The following is a description of a gene set: species: Homo sapiens Human Gene Set: GOMF_STRUCTURAL_CONSTITUENT_OF_CYTOSKELETON The action of a molecule that contributes to the structural integrity of a cytoskeletal structure., and this is the list of marker genes: GFAP, MSN, TUBB8, KRT15, CD2AP, ACTL7B, DSP, PLS1, VIM, TUBB1, SPTAN1, ACTR3, KRT19, TUBA8, INA, ARPC4, KRT2, POTEE, TUBA3C, TUBA1C, PLEC, PPL, NEFM, BFSP1, ACTL8, SPTBN1, KRT31, KRT9, YEATS4, ACTN2, POTEKP, KRT84, SPTB, LMNB2, ADD2, SPTBN4, BFSP2, ACTR2, TUBA1B, TUBB8B, TLN2, TUBB3, POTEF, EPB41L3, ACTG1, MYL9, SPTBN2, CCDC6, SPTA1, SYNM, LMNB1, TUBB4B (NCBI Gene Id 10383), CYLC1, TUBA4A, PRPH, TUBAL3, KRT14, EPB41L4B, TLN1, ANK1, TUBB6, TUBD1, KRT6B, TPM1, KRT5, TUBA3D, DMD, ARPC5, POTEJ, ACTA1, TUBGCP3, SORBS3, ARPC1B (actin related protein 2/3 complex subunit 1B), POTEI, CROCC, KRT6A, SORBS2, LORICRIN, ARPC2, DES, ACTB, TUBE1, TUBB2B, HIP1, ADD3, KRT16 (NCBI Gene Id 3868), ARPC3, TUBA1A, TUBB2A, DBNL, TUBA4B, EPB42, PLS3, EPB41, LMNA, TUBB, ACTBL2, CTNNA2, BICD1, NEFH, CYLC2, TUBGCP4, KRT20, ACTL7A, TUBA3E (NCBI Gene Id 150521), ANK2, TUBG1, NEFL, ERBIN, TUBB4A, ACTL6B, HLA-DRB1, VILL, ANK3, AGRN